Given this list of marker genes CRHR2, PEDS1-UBE2V1, S1PR2, ZNF823, POC1B, TBC1D2, FAM107B, CS, MTRF1L, C9orf72, REPS2, PIK3C2A, ARID4A, SIKE1, CCDC149, PABPC5, FOXP4 (NCBI Gene Id 116113), GRM6, LDLRAD4, ENTREP2, DEFB132 (NCBI Gene Id 400830), FN1, SLC25A27, GOLGA1, SPPL3, EXOC6B, ATRX, ARL8B, CHST4, SLC45A2, ROBO2, STIM2 (stromal interaction molecule 2), MRGPRX2, IPO9, UBN2, SEC23IP (NCBI Gene Id 11196), MAFF, GSE1, LPP, SPIRE1, LHFPL6, EPHB2, AGT, ZFP36L1, PPP2R5D, ENOX1, SHANK2, ZNF442, DICER1 (dicer 1, ribonuclease III), ANO6, ZNF131, ZFYVE21, PITPNC1, ANO1, MCC, REEP1, ZNF426, STRN3, GIGYF1, RAD54L2, RNMT, CCDC47, NR6A1, TERF2, B3GALNT2 (NCBI Gene Id 148789), CTTN, RUNX1T1, SLC6A14, SS18, DCUN1D3, SMIM8 (NCBI Gene Id 63914), ELF3, SNX25, CFTR, COL1A2, SYNDIG1L, ATPAF2, GPR139, PKP2, CREBRF, SIM1, C12orf42, RIMS2, PLEKHA1, PSME4, MRPL40, UBE2V1, LLPH, ZDHHC20, DSE (NCBI Gene Id 29940), GPM6B, ETV4, KIAA1210, STOX2, PPM1H, UBR7, IL21, SPOPL, RFX7, SKA3, NF1, TCOF1, NMU, ENSG00000255537, AIFM1, BORCS5, VEZF1, ZNF516, TPRG1, PABIR1 (NCBI Gene Id 116224), SUPT4H1, SH3GLB2, WWP1, FBXL14 (NCBI Gene Id 144699), KCNAB1, KLF6, LARP1, CTAGE1, ZNF44, SP1, USP38, GLS2, TBC1D9, MBNL3, PPM1L, TMEM108, FBXO22, HMGN1, HADH, SNAP25, ANKRD29, HOXD1, RIC8A, PCDH9, TPCN1, ZBTB41, JAM2, PCCA, PGD, JAK1, SKIDA1, SRBD1 (S1 RNA binding domain 1), AOC3, ARRB1, UMAD1, DSC1, CNOT6, MAIP1, KDM4C, CHSY1, PYY, here is a description of the gene set: from publication Chen Y, Wang X (PMID 31504780) Genes predicted to be targets of miRBase v22 microRNA hsa-miR-7114-5p in miRDB v6.0 with MirTarget v4 prediction scores > 80 (high confidence targets). Human Gene Set: MIR7114_5P species: Homo sapiens